The following is a description of a gene set: Human Gene Set: GAO_ESOPHAGUS_25W_C2_KRT6BPOS_SECRETORY_PROGENITOR_CELLS from publication Gao S, Yan L, Wang R, Li J, Yong J, Zhou X, Wei Y, Wu X, Wang X, Fan X, Yan J, Zhi X, Gao Y, Guo H, Jin X, Wang W, Mao Y, Wang F, Wen L, Fu W, Ge H, Qiao J, Tang F (PMID 29802404) studied in species Homo sapiens, and this is the list of marker genes: GK, TBC1D2 (NCBI Gene Id 55357), PDE9A (phosphodiesterase 9A), RNF103-CHMP3, TMPRSS11E, ADAM28, GIT2, ZFAND2A, MUC3A, NTHL1 (nth like DNA glycosylase 1), HTRA2, CEACAM1, PDZK1IP1, CYP2B7P, VCPKMT, MID2, SPNS2, PRSS27, GBP4, NTN4, DUOXA2, TMPRSS11D, MANSC1, DUSP5, BMAL2, SECTM1, GDPD3, ATP10B, STEAP4, NCCRP1 (NCCRP1, F-box associated domain containing), HOPX, KRT78, ZNF503-AS1, DUOX2, MBD6, LIPH, GAN, SPRR2A, IGF2BP2-AS1, ISG15, DUSP10, AGFG2, YJU2, TMPRSS11B, ST3GAL4, SLC15A1, CTSV, GPRC5A, OAS1, TGM2, MACC1, APOBEC3A, ADM, XDH, MUC21, CACNB1, LINC01559, MCPH1, MNX1, GPR160, BAHD1, PRSS22, BLNK, USP6NL, CALHM2, PDP1, GPT2, VASN, S100A8 (NCBI Gene Id 6279), KYNU, PRSS8, EPS8L1, ZNF710 (NCBI Gene Id 374655), CDKN2A, TOR1B, HDAC9 (NCBI Gene Id 9734), SLC6A14